Given this list of marker genes Gbp3, Acod1, Ddx41, Traf3ip3, Gbp6, Ifitm3, Ifi207, Ikbke, Oas1e, Gm12250, Oas1b, Ifi211, Mavs, Ifitm2, Ifi47, Gm4841, Irf1 (interferon regulatory factor 1), Gm11772, Ifi213, Ifi205, Ifit3, Ifi209, Ube2k, Cdc34, Ifitm6, Bst2 (bone marrow stromal cell antigen 2), Oas1a, Ifitm7, Oas1f, Camk2a, Mndal, Trex1, Ndufa13, Oas1g, Ifit1, Xaf1, Gm12185, Oas1h, Irgm1, Stat1, Hcn1, Gm5431, Ifnb1, Calm1, Gpr146, Trim6, Ifi204, Htra2, Calm2, Igtp, Ifitm1, Ifi202b, Ifi203, Sting1, Gbp2, Tlr3, Ifnar2, Ifi208, Capn2, Gbp7, Plscr1, Pnpt1, Tgtp1, Aim2, Oas1d, F830016B08Rik, Shfl, Calm3, Tgtp2, Ifi206, Iigp1, 9930111J21Rik1, Cdc34b, Ifnar1, Gbp2b, Ifi214, Ube2g2, Oas1c, Iigp1c, Irgm2, here is a description of the gene set: Any process that results in a change in state or activity of a cell or an organism (in terms of movement, secretion, enzyme production, gene expression, etc.) as a result of an interferon-beta stimulus. Interferon-beta is a type I interferon. Mouse Gene Set: GOBP_RESPONSE_TO_INTERFERON_BETA studied in species Mus musculus